Given this list of marker genes Nfe2l2, Epha4, Nol3, Vhl, Daxx, Eno1b, Eno1, Kdm6a, Drd2 (NCBI Gene Id 13489), Ogt, Hyou1, Tmbim6, Pink1, Commd1, Pik3cb (phosphatidylinositol-4,5-bisphosphate 3-kinase catalytic subunit beta), Ddah1, Drd1, Map2k1, here is a description of the gene set: studied in species Mus musculus Any process that stops, prevents or reduces the frequency, rate or extent of cellular response to hypoxia. Mouse Gene Set: GOBP_NEGATIVE_REGULATION_OF_CELLULAR_RESPONSE_TO_HYPOXIA